Given this list of marker genes TMOD3 (NCBI Gene Id 29766), MYBPC3, MYL4, MYH3, TNNT3, TPM1, TNNT1, TMOD4, ACTN2, TNNT2, TNNI3, TMOD2, ACTC1, TNNI2, DES, NEB, TNNC1, TCAP, TPM2, MYH6, MYBPC2, MYL3 (myosin light chain 3), TNNC2, ACTN3, ACTA1, TNNI1, MYL1, TMOD1, MYL2, DMD, TPM3, MYH8, TTN, VIM, TPM4, MYBPC1, here is a description of the gene set: Reactome Pathway: Striated Muscle Contraction Striated muscle contraction is a process whereby force is generated within striated muscle tissue, resulting in a change in muscle geometry, or in short, increased force being exerted on the tendons. Force generation involves a chemo-mechanical energy conversion step that is carried out by the actin/myosin complex activity, which generates force through ATP hydrolysis. Striated muscle is a type of muscle composed of myofibrils, containing repeating units called sarcomeres, in which the contractile myofibrils are arranged in parallel to the axis of the cell, resulting in transverse or oblique striations observable at the level of the light microscope.<br>Here striated muscle contraction is represented on the basis of calcium binding to the troponin complex, which exposes the active sites of actin. Once the active sites of actin are exposed, the myosin complex bound to ADP can bind actin and the myosin head can pivot, pulling the thin actin and thick myosin filaments past one another. Once the myosin head pivots, ADP is ejected, a fresh ATP can be bound and the energy from the hydrolysis of ATP to ADP is channeled into kinetic energy by resetting the myosin head. With repeated rounds of this cycle the sarcomere containing the thin and thick filaments effectively shortens, forming the basis of muscle contraction. species: Homo sapiens part of: Muscle contraction